Given this list of marker genes TOMM22, GAK, PRNP, ADAM8, GALM, NECTIN3, DPYSL2, CREBBP, LIPG, ABCC10, KGD4, RFC5, CXCL1, STARD7, KLHL18, PTHLH, NPDC1, SYT11 (synaptotagmin 11), POLK, TXN, MYO1G, FGF7, CEP72, MIAT, GSE1, GAS2L3, DUSP16, IGFBP3, EPS8, CLK4, ADIPOR2, PSEN1, MPST, LRIG1, VRK2, SEC11A, NETO2, ANKRD13A, AAGAB, MC3R, CARD14, HYAL4, DSCR9, AURKC, SETD1A, LGALS8, ECPAS, ANXA2, AP3D1, RAP1GDS1, LIMS1, DPPA4, BTBD7, STAG3L4 (NCBI Gene Id 64940), PHTF1, NXF3, NCOA2, BRSK1, SELENOS, TMEM45B, NUP62, TTL, GDAP2, TAF3, PWWP2A, MELK, SMIM31, RBPJ, TAS1R2, KBTBD8, ZNF625, SCGN, PHLDA2, SURF4, ANKRD12, TRRAP, COPZ2, HPS1, FKBP1B, SETD2, SRA1, KCTD20, FHOD1, AMDHD2, RTN4, CASC11, PRKCB, FERMT3, ODC1, PCLAF, MCRS1, FRAS1, EFNB1, FZR1, TENM1 (NCBI Gene Id 10405), TLCD4, CORO1C, FKBP11, PLEKHB2, HERPUD2, ZNF80, MGAT2, ACTR1A, ERBIN, ZNF547, LINC01720, CASC3, RP2, PLCB3, EXTL3, NEDD9, SETD7 (SET domain containing 7, histone lysine methyltransferase), CD58, ANO6, AREL1, THAP12, PEA15, MIR21, ZBTB6 (zinc finger and BTB domain containing 6), STK24, ATP6V1D, CEP89, ZSWIM6, SPAG9, EPN2, SUSD1, TXNDC11, EIF5A, ZFAND5, FDXACB1, CMTM3, HELLS, SPPL2A, RNF152, MTMR9 (NCBI Gene Id 83651), TAS2R7, GPR137B, AGL, DPY19L1, GNS, CNNM4, CYRIB, ITPK1 (inositol-tetrakisphosphate 1-kinase), ADAM22, RAB6A, ANO3, CXCL10, XPNPEP1, MDC1, TBK1, PYHIN1, CUZD1, MADD, VASH1, EXOSC1, SPMIP1, ELAPOR1, WSB2, TAF2, COX5A, SETD3, GTF2IRD2, YIPF6, CST2 (cystatin SA), MCOLN2, CSPG5, HEATR1 (NCBI Gene Id 55127), POLR3E, LRP2, EMX2, RASD1, ATG2A, ARHGAP5, CDKN1A, KCNJ2-AS1, CHMP2B, RTL6 (NCBI Gene Id 84247), FBXW7, SPRED2, PHAF1, CXCR4, TNIP2, TSPAN15, PTH2R, HAGHL, NAA40, ITPRIPL1, AMMECR1L, NME8, FBXO42, CSN1S2AP, RABGAP1L, DHCR7, here is a description of the gene set: species: Homo sapiens Human Gene Set: GSE26928_NAIVE_VS_CXCR5_POS_CD4_TCELL_DN Genes down-regulated in comparison of naive CD4 T cells versus CD4 CXCR5+ T cells. from publication Chevalier N, Jarrossay D, Ho E, Avery DT, Ma CS, Yu D, Sallusto F, Tangye SG, Mackay CR (PMID 21471443)